The following is a description of a gene set: Reactome Pathway: Toll Like Receptor 10 (TLR10) Cascade studied in species Mus musculus part of: Toll-like Receptor Cascades This event has been computationally inferred from an event that has been demonstrated in another species.<p>The inference is based on the homology mapping from PANTHER. Briefly, reactions for which all involved PhysicalEntities (in input, output and catalyst) have a mapped orthologue/paralogue (for complexes at least 75% of components must have a mapping) are inferred to the other species. electronically inferred by orthology from the curated human pathway, and this is the list of marker genes: Ube2n, Vrk3, Map2k7, Ecsit, Ubb, Map2k6, Lrrc14, Tab2, Dusp6 (NCBI Gene Id 67603), Hmgb1 (NCBI Gene Id 15289), Ube2v1, Nlrc5, Nkiras1, Ager (advanced glycosylation end product-specific receptor), Cul1, S100b, Tifa, Nfkb2, Map2k4, Rps6ka5, Mapk14, Peli2, Nfkb1, Mapk3, Ppp2r1b, Tab1, Ikbkb, Map2k3, Fos, Mapk11, Dusp7, Mapk9, Mapk8, Ppp2r5d (NCBI Gene Id 21770), Jun, Tab3, Nlrx1, Nfkbia, Mapk7, Nfkbib, Rps27a, Irak1, Map3k8, Casp8, Rela